The following is a description of a gene set: Organelle biogenesis and maintenance species: Mus musculus Mouse Gene Set: REACTOME_ORGANELLE_BIOGENESIS_AND_MAINTENANCE, and this is the list of marker genes: Atat1, Gbf1, Tmem216, Ift25, Dync2i2, Alms1, Haus5, Atp5pd, Rab11a, Cep152, B9d2, Mapre1, Arl13b, Ift80, Cnga4 (NCBI Gene Id 233649), Atp5f1a, Dctn2, Sirt4, Cep83 (centrosomal protein 83), Bbs9, Pcm1, Cc2d2a, Cep162 (NCBI Gene Id 78093), Ift46, Ssna1 (NCBI Gene Id 98824), Wdr19, Dync1i2, Rp2, Dync2h1, Cep78, Bbs4, Ttbk2, Inpp5e, Cep70, Tuba3b, Bbs1, Cep192, Rho, Exoc3, C2cd3, Sirt5, Tmem67, Dynlrb2, Cep89, Cluap1, Cep41, Pkd1, Wdr35, Cep131, Pde6d, mt-Atp6, Rab11fip3, Trip11, Rab3ip, Nde1, Haus8, Arl3, Tuba1a, Dynlt2a3, Atp5pf, Csnk1d, Dmac2l, Ift122, Traf3ip1, Tnpo1, Ahi1, Haus6, Plk4, Atp5pb, Gm10053, Hsp90aa1, Exoc5, Clasp1, Cenpj, Cep72, Sfi1, Pkd2, Atp5f1e, Dynlrb1, Tuba4a, Odf2, Ift74, Ift56, Kif3a, Cngb1, Cdk1, Haus4 (HAUS augmin-like complex, subunit 4, NCBI Gene Id 77461), Mks1, Tubb4b, Tubb4a, Ift22, Atp5f1d, Nek2, Kif3c, Prkaca, Haus7, Exoc2, Cep97, Cdk5rap2, Ckap5, Haus3, Cep290, Tubg1, Atp5f1b, Ift57, Rpgrip1l, Tubb2a, Atp5me, Tubb5, Sstr3, Gabpa, Glud1, Tuba1b, Idh2, Atp5mf, Dynlt2b, Sdccag8, Acss2, Dctn3, Cep250, Cycs, Cep164 (centrosomal protein 164), Ttc21b, Bbs5, Dync1h1, Atp5mk, Plk1, Csnk1e, Ift70a2, Rab8a, Sod2, Atp5mj, Arf4, Atp5mc2, Cep63, Haus2, Cep76, Ninl, Exoc8 (NCBI Gene Id 97490), Ift27, Exoc7 (exocyst complex component 7), Kifap3, Tuba3a, Mchr1, Ift43, Atp5mc1, Actr1a, Asap1, Tubb1, Pafah1b1, Sclt1, Septin2, Ywhag, Sirt3, Akap9, Tubal3 (NCBI Gene Id 238463), B9d1, Tuba8, Exoc4, Dynlt5, Ift52, Atp5f1c, Gabpb1, Tctn1, Ywhae, Ift140, Exoc1, Cep43, Dynll1, Cnga2, Nphp1, Nphp4, Dync2li1, Lztfl1, Tubb3 (tubulin, beta 3 class III), Cetn2, Ift70a1, mt-Atp8, Fbf1, Tctn2, Mark4, Tubb6, Ppp2r1a, Atp5po, Ttc8, Tubb2b, Ccp110, Iqcb1, Dynll2, Atp5mc3, Arl6, Atp5mg, Hdac6, Smo, Dctn1, Tuba1c, Unc119b, Tctn3, Dynlt2a1, Nedd1 (neural precursor cell expressed, developmentally down-regulated gene 1), Ift20, Kif24, Dync2i1, Bbs2, Ofd1, Ift70b, Nphp3, Kif17 (NCBI Gene Id 81001), Bbs7, Kif3b, Haus1, Cep135, Ift81, Ift172, Cep57